The following is a description of a gene set: Genes containing one or more binding sites for (Ndufs2) in their promoter regions (TSS -1000,+100 bp) as identified by GTRD version 20.06 ChIP-seq harmonization. Mouse Gene Set: NDUFS2_TARGET_GENES from publication Yevshin I, Sharipov R, Kolmykov S, Kondrakhin Y, Kolpakov F (PMID 30445619) studied in species Mus musculus, and this is the list of marker genes: Ctnna3, mt-Tn, Gm16170, Aloxe3, Gm13163, Ttc13, Mybbp1a, Arrdc3, Prr14, Gm9516, Nono, Nle1, Mir6922, Gm29609, Pomt1, Gcn1, Gm10222, H4c16, Ang, Gm26654, Mir1983, Bsg, Mettl26, Thap4, Rnf10, Duxf1, Odc1, Gm23751, Knl1, Fignl1, Gm6483, Fxr2, G530011O06Rikx, Eapp, Gm13421, Zfp992, Gm3264, Gm17638, Slc29a1, Smarcc2, Fbxo31, Dhps, 1700064H15Rik, Mir7068, Zfand2a, Mid1, Rnase4, mt-Ta, Cfap418, Zfp982, Ifrd2, Plekhg2, Acin1, 2610005L07Rik (NCBI Gene Id 436177), Mtch2, Pias4, Psmd3 (proteasome (prosome, macropain) 26S subunit, non-ATPase, 3), Cog1, mt-Td, mt-Tl1, Gm37450, 6820431F20Rik, Prr22, BB557941, mt-Tc, mt-Nd1, Atp5f1b, Rrp9, Polg, Spata31e2, Ylpm1, Paip1 (polyadenylate binding protein-interacting protein 1), Mir290a, Pdia6, Trim28, Ndufv1, Mir6968, Ppp1cc, Fmc1, Dohh, Ciapin1 (cytokine induced apoptosis inhibitor 1), 1700023H06Rik, Fkbp8, Abhd1, 4930477E14Rik, mt-Co2, Acp6, Wbp4, Gm15549, H4c8, Mymx (NCBI Gene Id 653016, myomixer, myoblast fusion factor), Gm11399, Arhgef2, Rhot2, Zfp36l1-ps, Dpp7, Ighv8-14, Gm13226, Foxred1, Agbl5, Mir291a, Mcoln1, Lta4h, Parp1, Ppp6r3 (NCBI Gene Id 75824), Mynn, Ptpa, 2610042L04Rik, Ndufs7, Ilf2, Prmt5 (protein arginine N-methyltransferase 5), Mir8105, mt-Tp, Gm15247, Psme3, Psmb3, Cox4i1, Ipo9 (NCBI Gene Id 98447), Acap3, B4gat1, Tmem181b-ps, Gm13228, Rab11a, Tia1, Gm40190, Sfi1, Mdn1, Gm26812, Vars2, mt-Ty, Cd81, Srebf1, Atp5f1a, Nomo1, Gm25541